Given this list of marker genes DHFR, MTHFS, DHFR2, MTHFD1L, FOLR1, MTHFD1, GCH1, DHFRP1, ATIC, SLC46A1, FPGS, here is a description of the gene set: species: Homo sapiens Human Gene Set: GOBP_FOLIC_ACID_CONTAINING_COMPOUND_BIOSYNTHETIC_PROCESS The chemical reactions and pathways resulting in the formation of folic acid and its derivatives.